The following is a description of a gene set: Formins are a family of proteins with 15 members in mammals, organized into 8 subfamilies. Formins are involved in the regulation of actin cytoskeleton. Many but not all formin family members are activated by RHO GTPases. Formins that serve as effectors of RHO GTPases belong to different formin subfamilies but they all share a structural similarity to Drosophila protein diaphanous and are hence named diaphanous-related formins (DRFs).<p>DRFs activated by RHO GTPases contain a GTPase binding domain (GBD) at their N-terminus, followed by formin homology domains 3, 1, and 2 (FH3, FH1, FH2) and a diaphanous autoregulatory domain (DAD) at the C-terminus. Most DRFs contain a dimerization domain (DD) and a coiled-coil region (CC) in between FH3 and FH1 domains. RHO GTPase-activated DRFs are autoinhibited through the interaction between FH3 and DAD which is disrupted upon binding to an active RHO GTPase. Since formins dimerize, it is not clear whether the FH3-DAD interaction is intra- or intermolecular. FH2 domain is responsible for binding to the F-actin and contributes to the formation of head-to-tail formin dimers. The proline-rich FH1 domain interacts with the actin-binding proteins profilins, thereby facilitating actin recruitment to formins and accelerating actin polymerization.<p>Different formins are activated by different RHO GTPases in different cell contexts. FMNL1 (formin-like protein 1) is activated by binding to the RAC1:GTP and is involved in the formation of lamellipodia in macrophages and is involved in the regulation of the Golgi complex structure. Activation of FMNL1 by CDC42:GTP contributes to the formation of the phagocytic cup. Activation of FMNL2 (formin-like protein 2) and FMNL3 (formin-like protein 3) by RHOC:GTP is involved in cancer cell motility and invasiveness. DIAPH1, activated by RHOA:GTP, promotes elongation of actin filaments and activation of SRF-mediated transcription which is inhibited by unpolymerized actin. RHOF-mediated activation of DIAPH1 is implicated in formation of stress fibers. Activation of DIAPH1 and DIAPH3 by RHOB:GTP leads to actin coat formation around endosomes and regulates endosome motility and trafficking. Endosome trafficking is also regulated by DIAPH2 transcription isoform 3 (DIAPH2-3) which, upon activation by RHOD:GTP, recruits SRC kinase to endosomes. DIAPH2 transcription isoform 2 (DIAPH2-2) is involved in mitosis where, upon being activated by CDC42:GTP, it facilitates the capture of astral microtubules by kinetochores. DIAPH2 is implicated in ovarian maintenance and premature ovarian failure. DAAM1, activated by RHOA:GTP, is involved in linking WNT signaling to cytoskeleton reorganization. Reactome Pathway: RHO GTPases Activate Formins part of: RHO GTPase Effectors studied in species Homo sapiens, and this is the list of marker genes: TUBB2A, MRTFA, DIAPH3, PFN1, SGO2, MAPRE1, SPC25, TUBA1B, FMNL3, DVL2, TUBA1C, ACTG1 (actin gamma 1), TAOK1, CENPI, NSL1, DYNC1I1, ERCC6L, PPP1CC, MAD1L1, CLIP1 (NCBI Gene Id 6249), AHCTF1, TUBB3, TUBB4A, PPP2R1B, CENPQ, CENPA, NUP98 (nucleoporin 98 and 96 precursor), ZWILCH, BIRC5, CENPK, TUBA4B, RPS27, DYNLL1, ITGB1, KIF2B, DYNLL2, DVL3 (NCBI Gene Id 1857), PPP2R1A, NDC80 (NDC80 kinetochore complex component), RHOB, SPDL1, SGO1, SCAI, CENPC, SRC, DYNC1I2, TUBA1A, PMF1, RANBP2 (NCBI Gene Id 5903), KNTC1, TUBB2B, TUBA8, TUBA3C, CENPE, TUBA3D, PPP2R5E, BUB1B, DYNC1H1, DSN1, SKA2, NDEL1, SPC24, SKA1, SRF, RHOA, CENPT, NUF2, CENPP, DVL1, PPP2R5B, ITGB3BP (NCBI Gene Id 23421), B9D2, FMNL2, MAD2L1, TUBB8B, DYNC1LI2, CENPF, CLASP1, AURKB, ZWINT, CLASP2, CENPU, CENPM, NDE1, RHOC, MIS12 (MIS12 kinetochore complex component), PPP2R5D, KIF2A, BUB3 (NCBI Gene Id 9184), CKAP5, TUBA4A, PPP2R5A, CDCA8, SEH1L, CENPL, RHOD, DIAPH1, EVL, NUP107 (NCBI Gene Id 57122), TUBB1, RANGAP1, RAC1, FMNL1 (formin like 1), XPO1, DYNC1LI1, TUBAL3, NUP133 (NCBI Gene Id 55746), ZW10, CDC42, INCENP, RCC2, PPP2CA, DIAPH2, CENPS (NCBI Gene Id 378708), CENPO, NUP85, SEC13, NUP43, DAAM1, PAFAH1B1, CENPH, NUP160, PFN2, NUP37, NUDC, PPP2R5C, KIF18A, CENPN, CDC20, ACTB, KIF2C, PPP2CB, TUBA3E, TUBB4B, KNL1, TUBB6, BUB1, SRGAP2, TUBB8, PLK1